Given this list of marker genes ATP7A, MFAP4, LTBP4, MYH11, EMILIN1, EFEMP2, COL3A1, TNXB, FBLN5, THSD4 (NCBI Gene Id 79875), LOX, here is a description of the gene set: Assembly of the extracellular matrix fibers that enables the matrix to recoil after transient stretching. species: Homo sapiens Human Gene Set: GOBP_ELASTIC_FIBER_ASSEMBLY